Given this list of marker genes Ikbkb, Cd4, Irf5, Insrr, Traf2, Trbv13-2, Ptk2b, Wnk1, Nup85, Trex1, Traf5, Ephb4, Il17ra, Ccr7, Lsm14a, Ifna1, Il5ra, Cxcl9, Cx3cr1, Ifna7, Irgm1, Slit3, Ifnlr1, Spata2, Naip2, Ticam2, Otop1 (otopetrin 1), Cntf, Lepr, Ntrk3, Mettl3, Cd74, Commd7, Socs3, Il3, Src, Wbp1l, Ccl24, Vrk2, Il7, Trim41, Il6, Dok1, Met, Tnfrsf4, Ifna15, Il4ra, Ifnab, Oas1b, Hax1, Usp27x, Ctnnb1, Ddr2, Oasl2, Il16, Adipoq, Csf3r, Ccl21a, Il1rl2, Il33, Sphk1, Casp1, Ifna5, Mpl, Stat1, Il10rb, Crebrf, Il17rd, Mmp12, Tjp2, Palm3 (NCBI Gene Id 74337), Cxcl10, Ppp2cb, Prl, Il31ra, Parp14, Il1r1, Ifnar1, Ext1, Trim56, Cxcl13, Adar, Nol3, Nfkbiz, Ythdf3, Txk, Il18rap, Lilra5, Oas1g, Csnk2b, Ikbke, Il36rn, Ptprc, Mcemp1, Ifitm1, Il1a, Tff2, Med1, Il6ra, Entrep1, Ephb1, Ptpn2, Musk, Csf2ra, Srsf1, C1qtnf4, Duox2, Numbl, Trim6, Gm13275, Il3ra, Crlf1, Bad, Igf1r, Ifnz, Gigyf2, Socs5, Ntrk1, Ccr10, Pdgfrb, Stat6, Ccl1, Mavs, Ifitm7, Gpr35, Il1rn, Il2, Edar, Ifitm3, Txndc17, Rabgef1, Ccr2, Cxcr1, Trp53, Gm13283, Erbb2, Sigirr, Il2rg, Myd88, Traf3ip2, Pira13, Tmc8, Tnfrsf11b, Actn4, Rps6ka5, Il1r2, Ifitm2 (interferon induced transmembrane protein 2), Tnfsf13b (tumor necrosis factor (ligand) superfamily, member 13b), Fer, Eed, Birc2, Ifih1, Irak4, Angpt1, Fzd4, Tyk2, Tek, Rps6ka4, Lifr, Ifnk, Epha8, Ephb2, Gpr75 (NCBI Gene Id 237716), Samhd1, Adipor2, Ifnb1, Zbp1 (NCBI Gene Id 80562), Cib1, Ifna11, Cxcr2, Ccr9, Il1f10, Ghr, Epha2, Il12rb2, Cactin, Rnf185, Slc1a1, Parp9, Ccl7, Traf1, Rraga, Rnf113a2, Tnfrsf1b, Cnot7, Rffl, Umod, Tnf, Stap1, Ttll12, Ltk, Flt3, Ebi3, Gm13277, Tnip2 (TNFAIP3 interacting protein 2), Cntfr, Yap1, Cd70, F3, Il18r1, Pira2, Oas2, Eif4e2, Dcst1, Rbck1, Smad4 (NCBI Gene Id 28063), Il12rb1, Stk39, Ifna14, Ccl21b, Cd44, Wnt5a, Il10ra, Nlrp6, Cpne1, Ccr6, Pirb, Oas1a, Egfr, Ccl9, Cish, Oas1e, Hpx, Epha4, Naip6, Mst1r, Trim32, Osm, Csf2rb, Pias3, Igtp, Nkiras2, Ret (NCBI Gene Id 19713), Usp29, Tbk1, Pafah1b1, Cd24a, Dicer1, Ntrk2, Ripk1, F2rl1, Plvap, Peli3, Hipk1, Tifa, Ccl26, Naip5, Il27ra, Ackr2, Insr, Ccr1, Sh2b2, Cxcl11, Xcl1, Apoa1, Gps2, Il21r (NCBI Gene Id 60504), Fosl1, Il13ra1, Ros1, Crlf2, Ccl4 (NCBI Gene Id 20303), Il4 (NCBI Gene Id 16189), Ccl8, Lyn, Jak1, Ccl6, Csf1r, Robo1, Epg5, Card14, Mt3, Ythdf2, Grem2, Adam17, Il17rb, Irak2, Stat5a, Birc7, Tirap, Il15ra, Ccr3, Syk, Fcer1g, Cldn18, Jak3, Pdgfra, Ifitm6, Gab1, Irf7, Isg15, St18, Edn1, Ifne, Il17rc, Map3k7, Cdip1, Lims1, Kdr, Tnfsf11, Ccl12, Stat4, Slc27a1, Pparg, Cxcr3, Hif1a, Il23r, Il22ra1, Axl, Cnot9, Socs2, Epha5, Tollip, Socs4, Ecm1, Nfkbia, Fbxo21, Smim30, Il1b, Epha7, Tut4, Irak1, Mmp8, Epo, Il2rb, Ackr1, Stat2, Il20rb, Ccl2, Ripk2, Ccr5, Epha6, Il11ra1, Irgm2, Il18, Ifna13, Appl1, Tnfrsf18, Cd40, Hdac4, Ccl22, Fgfr2, Appl2, Cd300lf, Foxc1, Cxcr5, Nlrc5, Pdgfb (platelet derived growth factor, B polypeptide), Dnaja3, Csf2rb2, Xiap, Ceacam1, Ccl5, Sh2b3, Xcr1, Tnfrsf17, Nkiras1, Trem2, Acbd7, Sin3a, Plcb1, Rack1, Il1rap, Cyld, Ccl3, Pira12, Trim44, H2bc21, Alk, Epha1, Irf1, Cx3cl1, Jak2 (NCBI Gene Id 98155), Il6st, Sting1, Ccr4, Mertk, Il36g, Il10, Fadd, Ifnar2, Sirt1, Trim65, Lep, Nr1h4, Ccr8, Ddr1, Rnf31, Prlr, Il11, Ccl19 (NCBI Gene Id 24047), Ereg, Il17f, Prmt2, Ifna12, Edn2, Cdc37, Pik3r1, Stat5b (signal transducer and activator of transcription 5B), Ctr9, Il5, Ugcg, Mul1, Nsmaf, Bbs4, Eda2r, Ifna9, Akt1, Ifna2, Slit2, Il22ra2, Kras, Duox1, Il7r, Ptprf, Oas1h, Hspa1b, Il15, Oas1c, Il1rl1, Irs1, Flt4, Ifna4, Ifng, Otud4, Tmsb4x, Iigp1, Irak3, Cxcl12, Il36a, Krt18 (keratin 18), Eda, Krt8, Adipor1, Mkks, Traf3, Gm13271, Ptpn6, Muc19, Tnfrsf13c, Sharpin, Cav1, Erbb4, Fgfr1, Oas3, Il34, Socs1, Epor, Padi2, Rbm15, Il9, Traf6, Fgfr3, Ilk, Il1rapl2, Spi1, Ccr1l1, Ikbkg, Ccl11, Oas1f, Tslp, Tie1, Egr1, Il11ra3, Epha10, Csf1, Pycard, Fkbp1a, Traip, Kit, Acsl1, Mir301, Ror2, Inhba (NCBI Gene Id 16323), Il9r, Tnfsf18, Ackr4, Il12a, Il17re, Ccdc3, Fgfr4, Il13, Casp4, Tnfrsf11a, Ifngr1, Il13ra2, Gas6, Tank, Ackr3, Ifngr2, Cxcr4, Chuk, Stat3, Prkn, Mapk3, Gm13272, Il12b, Zc3h15, Oas1d, Ephb3, Rela, Rbm47, Irf3, Tnfrsf1a, Cebpa, Osmr, Bbs2, Gfi1, Il17a, Il36b, Usp18, Rnf113a1, Ccl25, Arg1, Lilra6, Oxsr1, Pias4, Ube2k, Pf4, Foxo3, Thpo, Hcls1, Epha3, Il11ra2, Naip1, Notch1, Cxcr6, Usp25, Aim2, Cxcl17, Gpr108, Klf6 (NCBI Gene Id 97911), Gm13276, Csf3, Ifna6, Tyro3, Ifna16, Oasl1, Il20ra (interleukin 20 receptor, alpha), Flt1, Laptm5, Csf2, Ccrl2, P3r3urf, Otulin, Jagn1 (NCBI Gene Id 67767), Il2ra, Tradd, here is a description of the gene set: studied in species Mus musculus Mouse Gene Set: GOBP_CYTOKINE_MEDIATED_SIGNALING_PATHWAY The series of molecular signals initiated by the binding of a cytokine to a receptor on the surface of a cell, and ending with the regulation of a downstream cellular process, e.g. transcription.